The following is a description of a gene set: Enables the transfer of salt from one side of a membrane to the other. studied in species Mus musculus Mouse Gene Set: GOMF_SALT_TRANSMEMBRANE_TRANSPORTER_ACTIVITY, and this is the list of marker genes: Slc23a1, Slc22a13, Abcg2, Slc2a9 (NCBI Gene Id 231167), Slc17a4, Slc22a12, Abcg3, Slc17a2, Slc17a3, Abcc4